Given this list of marker genes MAG, H2AB3, FAM216B, TLN1, HECTD4, G6PC3, PPP1R9B, ZC3H11C, FXR2, NUTM2A, POM121, ESRP2, SLC6A11, H2AB1, SLC24A1, PPP1R16B, CRABP2, IL22, PAX9, LIAT1, LMO7, CREBBP, IGF2BP3, ZNF215, DDX42, CLIP3, ZNF32, H2AB2, PRRX2, PPP3CB, MECP2, ZCCHC24, ZC3H11A, VAPB, AGAP1, OSBPL3, RCAN2, SLC25A23, ELAVL3, EIF5, HEXIM1, BCL2, NELFE, ENSG00000187185, TCHP, IGF2, ARHGEF33, SGMS1, TGFBR3, NR2E3, PCSK2, CALCOCO1, GAS7, CREG1, IL36B, ZNF629, SNX4, RALGPS1, CACNA1E (calcium voltage-gated channel subunit alpha1 E), ST8SIA3, NUTM2B, UNC13C (NCBI Gene Id 440279), CEP85L, ASIC1, CNTNAP1, PRAF2, PKNOX2, CBX6, GON4L, PRX, STAT6, CRTC3, here is a description of the gene set: Genes predicted to be targets of miRBase v22 microRNA hsa-miR-4260 in miRDB v6.0 with MirTarget v4 prediction scores > 80 (high confidence targets). from publication Chen Y, Wang X (PMID 31504780) studied in species Homo sapiens Human Gene Set: MIR4260